Given this list of marker genes Nfe2l2, Dhfr (dihydrofolate reductase), Epor, Cd36, Sesn3, Adcyap1r1, Sesn2, Fbln5 (NCBI Gene Id 23876), Gch1, Sesn1, here is a description of the gene set: species: Mus musculus Any process that modulates the frequency, rate or extent of response to reactive oxygen species. Mouse Gene Set: GOBP_REGULATION_OF_RESPONSE_TO_REACTIVE_OXYGEN_SPECIES